The following is a description of a gene set: species: Homo sapiens Human Gene Set: MODULE_12 Spinal cord (neuro-development) genes., and this is the list of marker genes: UBL3, CXCL1, KIF5C, DAB2, CNP, NCAN, H2BC21, CDKN1A, GAS1, BMERB1, FCGRT, CHST15, MAOB, ADM (NCBI Gene Id 133), SLIT2, GET1, NOTCH3, DNAJB2, NEFL, SRRM2, DNM2, GRIA2, IGFBP4, SLC11A2, GNAI1, DTX4, NEBL, PCOLCE, TRIM16, FGF1, TRO, GABBR1, INA, OMG, STMN2, DST, BCL6, CRIM1, AP1S2, GPX3, S100A11, PENK, GPM6A, GFAP, PTX3, CDK18, RGS1, MIR9-1HG, FXYD1, TNFAIP3, COL6A1, ZIC1, ENO2, FEZ1, ID2B, IL6, F3, BCAS1, ECHS1, FBLN1, PCBP4, COL6A3, TYRO3, CXCL8, ST3GAL5, S100A8, LOX, PTN, FAT1, WASF3, ARHGEF4 (Rho guanine nucleotide exchange factor 4), NR1D1 (NCBI Gene Id 9572), DNM1, ZBTB20, G0S2, DDX21, MAL, SMTN, TNC, MSMO1, PCDH9, WDR7, MLLT11, KLK6, TLE2, COL4A1, NR2F1, SELENOP, ALDH7A1, CCND1, PAX4, COL5A2, FERMT2, CNN3, KIAA0513, ELN, THRA, ERBB3, SERPINH1, CDC42EP1, UGT8, ITM2A, DAAM2, ARHGEF6 (NCBI Gene Id 9459), CYP1B1, AUTS2, LMO3, ZBTB16, TNFAIP2, PEG3, MTUS1, L1CAM, PLP1, ATP1B2, FAM107A, DCLK1, NR4A1, CRABP1, SYNGR1, IGFBP2, GAP43, TMEM63A, DHRS3 (NCBI Gene Id 9249), FOS, GFPT2, LPL, PAX6, LRP1, LAMB2, COL15A1, MYRF, SATB1, SOX10, IFIT1, ITGA6, TPM1, DLX4, PCP4, CYB561 (NCBI Gene Id 1534), COL1A2, FOSB, SLC23A2, PLEC (plectin), FGFR1, TRIB2, ARNT2, IFI44L, PTPN13, COL16A1, PRSS2, SERPINE1, ME1, PER1, SRI, GRIN1, CXCL2, MYH11, GSTM1, CPE, GMPR, C1S, NNAT, EPB41L2, NAMPT, LDLR, FBXL7, APOD, EDNRB, DDIT4, AKR1C1, RHOBTB3, COL3A1, ALCAM (activated leukocyte cell adhesion molecule), RAB31, SLC1A3, APLP1, TCEAL4, MGLL, MFAP2, VSNL1, CX3CL1, CD14, APBA2, NEFM, NCAM1, EEF1A2, S100B, VSIG4, LIPA, SEPTIN10P1, CCL2, ANXA1, MARF1, FN1, EPB41L3, WWTR1, COL1A1, POU2F3, APOC1, SERPINA3, C1QB, IGFBP3, SOX9, TJP2, SLPI, SGCE, TIMP3, ADIPOR2, ECM2, ENG, ITGA7, SRPX, LAPTM5, NTRK2, NOVA1, SERPINI1, ARHGEF10, TRIM2, RTN1, TSPYL2, PTPRZ1, RHOB, DEPP1, HSPG2, ASAH1, DSP, PON2, HOPX, RARRES2, PIK3C2B, FBN2, SH3GL3, MPZ, LHFPL2, KRT86, USP6, MLC1, COL9A3, GPC3, PALM, CAV1, CCND2, IGFBP6, PLAAT3, VAMP5, GNG12 (NCBI Gene Id 55970), SV2A, GJB1, GOLGA8A, COLGALT2 (collagen beta(1-O)galactosyltransferase 2), SST, EMP3, PEG10, GJA1, SPP1, ZEB1 (NCBI Gene Id 6935, zinc finger E-box binding homeobox 1), ABLIM1, COL11A1, SNAP25, POSTN, CADM1, TGM2, JUNB (NCBI Gene Id 90482), GOT1, NUPR1, RGS16, FOSL2, AQP4, FADS2, GPRC5B, ANK3, GATM, CLIP3, CDH2, SLC2A3, REG1A, HMOX2, THBS2, ACKR1, TLE1, MYLK, GSTA4, TSPAN7, RNASE1, ZYX, SFRP1, AEBP1, SYNM, HES1, CRMP1, TNFRSF1B, PDGFRA, EFS, STK39, ATP9A, APOE (apolipoprotein E), CLEC3B, VEGFA, ITGB4, DBN1, ABCA3, AHDC1, DIP2C, SYT11 (NCBI Gene Id 92303), CDKN1C, BIN1, RBP1, MAPK8IP3, HSPA2, CRYAB, MBP, FGFR3, CLDN5, MYL9, ENPP2, DPP6, PCDH17, LDOC1, ALAS2 (5'-aminolevulinate synthase 2), ANOS1, SNCG, CCN1, TMEM47, FABP7, ATP6V0A1, NGFR, CX3CR1, COL6A2, PDE4B, AQP1, LMO4, AGT, SRGN (serglycin), CSPG4, APBB1, DPYSL3, CHRNB1, ABAT, TFAP2B, QDPR, STAB1, PDLIM5, DEFA3, VCAN, MEGF9, FKBP8, SLC39A6, SCG5, IGF2, PTGDS, RASSF2, MAPRE2, SCHIP1, FADS1 (NCBI Gene Id 3992), PDE8A, SLC4A4, TGFBI, ATP10B, TSPAN3, ISG15